Given this list of marker genes ZNF143, POLR2L, POLR2F, POLR3F, BDP1, POLR2H, SNAPC1, POLR1D, POLR3C, SNAPC4, POLR3G, SNAPC2, POLR1C, POLR3A, POLR3D, POLR3H, CRCP, SNAPC3, SNAPC5, POLR2K, POLR3GL, POLR3E, POLR2E, POLR3K, POLR3B, POU2F1, BRF2, TBP (NCBI Gene Id 6908), here is a description of the gene set: species: Homo sapiens Human Gene Set: REACTOME_RNA_POLYMERASE_III_TRANSCRIPTION_INITIATION_FROM_TYPE_3_PROMOTER RNA Polymerase III Transcription Initiation From Type 3 Promoter